The following is a description of a gene set: Sphingosine 1-phosphate (S1P) pathway Human Gene Set: PID_S1P_META_PATHWAY from publication Schaefer CF, Anthony K, Krupa S, Buchoff J, Day M, Hannay T, Buetow KH (PMID 18832364) studied in species Homo sapiens, and this is the list of marker genes: S1PR5, SGPL1, SPHK1, GNAQ, GNA12, S1PR3, SGPP1, GNAO1, SPHK2, ABCC1, GNA14, S1PR1, GNA11, GNAI2, GNAI3, GNA13, S1PR2, GNAZ, GNA15, GNAI1, S1PR4